Given this list of marker genes TP73, MAP3K7, RET, PRR16, AMOT, KDM1A, HSP90AA1, AKT3, EDN1, PRKD1, SLC26A5, RB1CC1, here is a description of the gene set: studied in species Homo sapiens Human Gene Set: GOBP_POSITIVE_REGULATION_OF_CELL_SIZE Any process that increases cell size.